The following is a description of a gene set: Human Gene Set: GOBP_GUANINE_NUCLEOTIDE_TRANSPORT The directed movement of guanine nucleotides, GTP, GDP, and/or GMP, into, out of or within a cell, or between cells, by means of some agent such as a transporter or pore. species: Homo sapiens, and this is the list of marker genes: ABCC5, SHOC2, LRRC8D, SLC17A9, ABCC4, SLC46A2, SLC19A1, LRRC8C, LRRC8A, LRRC8E, LRRC8B